Given this list of marker genes H2BC21, H2BC14, H2AC14, H2AB1, UHRF1, H2BC12L, H3C15, H2BC15, H2AC20, H2BC3, H2BC5, H2AJ, DNMT3A, H2AC7, H2BC4, H2BC17, DNMT3L, DNMT1, H2BC12, H2AC18, H2BC11, DNMT3B, H2AX, H2BC13, H3-3A, H2AC6, H3C1, H2BC26, H2BC1, H2BC9, H2AZ2, H4C1, H2AC4, here is a description of the gene set: part of: Epigenetic regulation of gene expression Reactome Pathway: DNA methylation Methylation of cytosine is catalyzed by a family of DNA methyltransferases (DNMTs): DNMT1, DNMT3A, and DNMT3B transfer methyl groups from S-adenosylmethionine to cytosine, producing 5-methylcytosine and homocysteine. (DNMT2 appears to methylate RNA rather than DNA.) DNMT1, the first enzyme discovered, preferentially methylates hemimethylated CG motifs that are produced by replication (template strand methylated, synthesized strand unmethylated). Thus it maintains existing methylation through cell division. DNMT3A and DNMT3B catalyze de novo methylation at unmethylated sites that include both CG dinucleotides and non-CG motifs.<br>DNA from adult humans contains about 0.76 to 1.00 mole percent 5-methylcytosine. Methylation of DNA occurs at cytosines that are mainly located in CG dinucleotides. CG dinucleotides are unevenly distributed in the genome. Promoter regions tend to have a high CG-content, forming so-called CG-islands (CGIs), while the CG-content in the remaining part of the genome is much lower. CGIs tend to be unmethylated, while the majority of CGs outside CGIs are methylated. Methylation in promoters and first exons tends to repress transcription while methylation in gene bodies (regions of genes downstream of the promoter and first exon) correlates with transcription. Proteins such as MeCP2 and MBDs specifically bind 5-methylcytosine and may recruit other factors.<br>Mammalian development has two major episodes of genome-wide demethylation and remethylation. In mice about 1 day after fertilization the paternal genome is actively demethylated by TET proteins together with thymine DNA glycosylase and the maternal genome is demethylated by passive dilution during replication, however methylation at imprinted sites is maintained. The genome has its lowest methylation level about 3.5 days post-fertilization. Remethylation occurs by 6.5 days post-fertilization. The second demethylation-remethylation event occurs in primordial germ cells of the developing embryo about 12.5 days post-fertilization. DNMT3A and DNMT3B, together with the non-catalytic DNMT3L, play major roles in the remethylation events. How the methyltransferases are directed to particular regions of the genome remains an area of active research. The mechanisms at each locus may differ in detail but a connection between histone modifications and DNA methylation has been observed. species: Homo sapiens